The following is a description of a gene set: Human Gene Set: BILANGES_RAPAMYCIN_SENSITIVE_GENES from publication Bilanges B, Argonza-Barrett R, Kolesnichenko M, Skinner C, Nair M, Chen M, Stokoe D (PMID 17562867) Genes translationally regulated in MEF cells (embryonic fibroblasts) by rapamycin (sirolimus) but not in response to serum deprivation. studied in species Mus musculus The tuberous sclerosis complex (TSC) proteins TSC1 and TSC2 regulate protein translation by inhibiting the serine/threonine kinase mTORC1 (for mammalian target of rapamycin complex 1). However, how TSC1 and TSC2 control overall protein synthesis and the translation of specific mRNAs in response to different mitogenic and nutritional stimuli is largely unknown. We show here that serum withdrawal inhibits mTORC1 signaling, causes disassembly of translation initiation complexes, and causes mRNA redistribution from polysomes to subpolysomes in wild-type mouse embryo fibroblasts (MEFs). In contrast, these responses are defective in Tsc1(-/-) or Tsc2(-/-) MEFs. Microarray analysis of polysome- and subpolysome-associated mRNAs uncovered specific mRNAs that are translationally regulated by serum, 90% of which are TSC1 and TSC2 dependent. Surprisingly, the mTORC1 inhibitor, rapamycin, abolished mTORC1 activity but only affected approximately 40% of the serum-regulated mRNAs. Serum-dependent signaling through mTORC1 and polysome redistribution of global and individual mRNAs were restored upon re-expression of TSC1 and TSC2. Serum-responsive mRNAs that are sensitive to inhibition by rapamycin are highly enriched for terminal oligopyrimidine and for very short 5' and 3' untranslated regions. These data demonstrate that the TSC1/TSC2 complex regulates protein translation through mainly mTORC1-dependent mechanisms and implicates a discrete profile of deregulated mRNA translation in tuberous sclerosis pathology., and this is the list of marker genes: ACSL1, SREK1, TNFAIP2, NEU1, LRRC41, RPS15, TPRN, NUDT7, RPL22, TBC1D16, BRI3BP, BRAP, MED23, PPWD1, TADA1, RPL35, HAP1, RPL23A, SMC2, INSIG1, ITGA6, PRCC, SHTN1, SLC12A9, RPL11, N4BP3 (NEDD4 binding protein 3), GPD2, EDC4, RPL34, POLR1B, RPL27, SAT1, RAMP3, DHX35, SLC26A1, PPM1L, TMEM179